Given this list of marker genes SCYL1, NFE2L1, LHX3, NKX2-2, OLIG3, CLN8, OLIG2, GLI3, TBX20, ZC4H2, LMO4, LBX1, HOXC10, DYNC2H1 (dynein cytoplasmic 2 heavy chain 1), HOXD10, MNX1, IFT172, GBX1, PHOX2A, ISL1, PTCH1, MDGA2, SUFU, SHH, ISL2, SCYL3, LONRF2, ABT1 (activator of basal transcription 1), LHX4, GIGYF2, TCTN1, here is a description of the gene set: Human Gene Set: GOBP_SPINAL_CORD_MOTOR_NEURON_DIFFERENTIATION The process in which neuroepithelial cells in the ventral neural tube acquire specialized structural and/or functional features of motor neurons. Motor neurons innervate an effector (muscle or glandular) tissue and are responsible for transmission of motor impulses from the brain to the periphery. Differentiation includes the processes involved in commitment of a cell to a specific fate. studied in species Homo sapiens